The following is a description of a gene set: DENV infection starts in skin cells after a bite by an infected mosquito. The receptor(s) for DENV infection of keratinocytes is unknown. Subsequently, macrophages get infected and spread the virus out of the skin. DENV replicates in many cell lines but in vivo, DENV replicates only in few cell types. The most extensively studied organs/tissues where DENV was not only present but also replicated are skin, peripheral blood, spleen, lymph node and liver. The Dengue virus is enveloped and the envelope is covered with a glycoprotein known as the E protein (envelope protein). E protein is responsible for mediating the attachment and entry of the virus into host cells. PrM protein (Precursor Membrane Protein) helps stabilize the E protein in the course of virion assembly and is cleaved during virus maturation, leaving the M fragment bound to E.<br><br>The Dengue virus can attach to a variety of host cell receptors, depending on the cell type and the serotype of the virus. Some of the known receptors and attachment factors include: CD209 (also known as DC-SIGN, Dendritic cell-specific intercellular adhesion molecule-3-grabbing non-integrin), or CLEC4L (C-type lectin domain family 4 member L; Tassanetrithep et al., 2003), heparan sulfate, heat shock proteins HSP70 and HSP90 (Reyes-Del Valle et al., 2005), RPSA (also known as Small ribosomal subunit protein uS2, 67 kDa laminin receptor, 67LR, LAMR1, or LAMBR), GAS6 (also known as Growth arrest-specific protein 6, AXL receptor tyrosine kinase ligand, or AXLLG) and PROS1 (also known as Vitamin K dependent protein S, PROS), and the macrophage mannose receptor MRC1.<br>It is generally agreed that CD209 is the main receptor for Dengue virus entry in dendritic cells (DCs). CD209 is a receptor on DCs and macrophages that binds to the E protein of the Dengue virus. Genetic variations in CD209 may influence susceptibility or resistance to dengue virus infection, as well as disease progression and severity. A promoter polymorphism in the CD209 gene is associated with protection from dengue fever, but not dengue hemorrhagic fever.<br><br>GAS6 plays a role in Dengue virus entry by apoptotic mimicry. Apoptotic mimicry is a strategy used by some pathogens to evade the host's immune system by mimicking the characteristics of apoptotic cells to enter the host cells without triggering a strong immune response. In apoptotic cells, phosphatidylserine (PtdSer) externalization occurs, where PtdSer flips from the inner to the outer leaflet of the plasma membrane. External PtdSer serves as a signal that promotes recognition and phagocytosis of dying cells by macrophages and other phagocytes without triggering inflammation. The Dengue virus displays PtdSer on its envelope, allowing it to bind to TIM and TAM receptors on phagocytic cells and to enter the phagocytes via a pathway they normally use to engulf apoptotic bodies. TIM receptors TIM1, TIM3, and TIM4 can directly interact with the Dengue virion-associated PtdSer, with TIM1 and TIM4 potentiating the infection most significantly, while TIM3 had a modest effect. TAM receptors AXL and TYRO3 interact with the Dengue virion-associated PtdSer indirectly, with the TAM receptor ligands GAS6 and PROS (Protein S) serving as a bridge to bind to the virion PtdSer. In neural cells, prohibitin 1/2 (PHB1, PHB2) has been identified as DENV-3 receptor.</p><p>After attachment, the Dengue virion is typically taken into the cell through a process known as receptor-mediated endocytosis. Inside the endosome, the acidic environment triggers a conformational change in the E protein. This change allows the viral envelope to fuse with the endosomal membrane, releasing the viral RNA into the cytosol of the host cell, where replication and translation can begin. For a review of DENV attachment and entry see Cruz-Oliveira et al., 2015. species: Homo sapiens Reactome Pathway: Dengue Virus Attachment and Entry part of: Dengue Virus Infection, and this is the list of marker genes: PROS1, TIMD4, SDC1, UBA5, GPC6, LY6E, FURIN, GPC2, AP2A1, GPC5, GAS6, PIK3R1, UBA3, EMC4, HSPG2, AP2A2, TYRO3, UBA7, MRC1 (mannose receptor C-type 1), AXL, CLDN1, ATG7, DENCMEMSB, AP2M1, UBA6, CD33, CD14, SDC2, CD300A, HAVCR1, GPC1, RPSA, HSPA5, GPC3, UBA1, CD209, MERTK, AP2B1, AGRN, SDC3, AP2S1, MAPRE3, GPC4, SDC4, RNASEK